Given this list of marker genes Rpl29, Fau, Rpl27a, Rps4x, Rps2, Rpl23a, Eif3b, Rpl4, Eif3e, Rpl15, Rps28, Rps10, Rpl11, Rpl39l, Rpl24, Rps6, Rpl6, Rps12, Rps20 (NCBI Gene Id 67427), Rpl26, Rps25, Eif3j2, Rpl27, Eif3k, Rpl37a, Rps7, Rpl18 (NCBI Gene Id 19899), Rps5, Rps13, Eif1ax, Eif3f, Rpl19, Rpl14, Rpl38, Rpl3, Rps11, Eif3i, Rps19, Rpl3l, Eif3d, Rpl37, Rpl13, Rps23, Rpl12, Rpl7, Rps24, Ubb, Rpl36al, Rpl37rt, Rps9, Rpl36a, Eif3g, Rps17, Rps26, Rps3a1, Rpl9, Rpl18a, Rpl39, Rps27l, Rps18, Rps8, Rps15, Rplp2, here is a description of the gene set: electronically inferred by orthology from the curated human pathway part of: Cap-dependent Translation Initiation studied in species Mus musculus This event has been computationally inferred from an event that has been demonstrated in another species.<p>The inference is based on the homology mapping from PANTHER. Briefly, reactions for which all involved PhysicalEntities (in input, output and catalyst) have a mapped orthologue/paralogue (for complexes at least 75% of components must have a mapping) are inferred to the other species. Reactome Pathway: Formation of a pool of free 40S subunits